The following is a description of a gene set: Mouse Gene Set: CUI_T_CELL_CD4_IL7_RESPONSE_DN Genes negatively differentially expressed in cell type: CD4+ T cell upon treatment with cytokine: IL-7 in mouse lymph nodes in vivo. Cytokines mediate cell-cell communication in the immune system and represent important therapeutic targets. A myriad of studies have highlighted their central role in immune function, yet we lack a global view of the cellular responses of each immune cell type to each cytokine. To address this gap, the authors created the Immune Dictionary, a compendium of single-cell transcriptomic profiles of more than 17 immune cell types in response to each of 86 cytokines (>1,400 cytokine-cell type combinations) in mouse lymph nodes in vivo. A cytokine-centric view of the dictionary revealed that most cytokines induce highly cell-type-specific responses. For example, the inflammatory cytokine interleukin-1β induces distinct gene programmes in almost every cell type. A cell-type-centric view of the dictionary identified more than 66 cytokine-driven cellular polarization states across immune cell types, including previously uncharacterized states such as an interleukin-18-induced polyfunctional natural killer cell state. studied in species Mus musculus from publication Cui A, Huang T, Li S, Ma A, Pérez JL, Sander C, Keskin DB, Wu CJ, Fraenkel E, Hacohen N (PMID 38057668), and this is the list of marker genes: Rflnb, Pde7a, H2az2, Btg2, Gimap1, Ddit4, Il7r, Ipcef1, Ypel3, Cd52, Cd3g, Snx20, Chd3, Cd28 (NCBI Gene Id 12487), Itpkb, Cd27, S100a11, Tdrp, Ctsd, Ahnak, Utrn, Hspa1b, Hspa1a, Cd4, Smc6, Zfp36l2, Neurl3, Tnrc6b, Klhl24, Zbtb20, Cox7a2l, Malt1, Crlf3, Esyt2, Saraf, Eef2, Rnf167, Cd5, Fyb1, Rgs10, Sesn3, Scp2, Gramd1a, Kif21b, Tsc22d3, Ighm (NCBI Gene Id 432703), Prex1, Madd, Cd3d, Supt4a, Tcf7 (NCBI Gene Id 21414), Stk4, Selenop, 9930111J21Rik2, Uqcrh, Stap1, Myh9, Actn1, Arl5c, Trp53inp1, Tent5c, Gimap6, Lsp1, Mxd4, Jun, Itga4, Adcy7, Hcst, Stim1 (stromal interaction molecule 1), Emb, Entrep3, Fam78a, Tgfbr2 (transforming growth factor, beta receptor II), Satb1 (special AT-rich sequence binding protein 1), Pdcd4, Dapl1, S100a10, Crip1, St8sia6, Elf1, Gmfg, Pik3ip1, S100a6, Smc4